The following is a description of a gene set: studied in species Mus musculus Mouse Gene Set: GOBP_CELLULAR_RESPONSE_TO_ALCOHOL Any process that results in a change in state or activity of a cell (in terms of movement, secretion, enzyme production, gene expression, etc.) as a result of an alcohol stimulus., and this is the list of marker genes: Jup, Drd2, Mir10b, Tnfsf4, Gpld1, Btg2, Akr1c18, Npas4, Foxo3, Hnrnpk, Cftr, Ces1d, Golph3, Sod2, Inhbb, Mir30a, Mlc1, Mir362, Aifm1, Dynapl1, Mir200a, Ahr, Acaca, Creb1, Fbp1, Fancb, Fos, Map4k1, Mir30e, Ptger2, Adcy8, Gramd1b, Adcy3, Scnn1b, Ces1b, Sgk1, Blm (NCBI Gene Id 12144), Spidr, Gramd1a, Glra2, Mir9-3, Mir10a, Cyp7a1, Ces1f, Ctnna1, Mir154, Dnmt3a, Pten, Rplp0, Abca1, Prkaa2, Brca1 (breast cancer 1, early onset), Ces1h, Sfrp1, Ptger3, Efna5, Cdh1, Ptgfr, Hdac8, Lancl2, Slc5a5, Adcy7, Gnai1, Rps6, Ugt1a1, Akt1, Rad51, Gnas, Mir145a, Hnf1a, Klf4, Arpc2, Adam15, Gpr155, Osbpl7, Glra1, Fdx1, Cdk4, Klf2, Slc23a2, Trp53inp1, Akap8, Cyp1b1, Gramd1c, Nfe2l1, Mir9-1, Adcy5, Sphk2, Hoxa1, Nr3c2, P2ry4, Ctnnb1, Dag1, Scnn1g, Ccl7, Recql5 (NCBI Gene Id 170472), Lrp6, Kcnmb1, Ptgdr, P2ry6, Mir152, Dynap, Nanog, Epha5, Lrp8, Grip1 (glutamate receptor interacting protein 1), Klf9, Ireb2, Prkce, Tnc, Itpr2, Ces1a, Prkaa1, Adcy6, Mir9-2, Ncam1, Larp1, Mdm2, Adcy2, Rps6-ps4, Mir496a, Mir296, Smo, Scnn1a, Ptch1, Cybb, Ucp1, Ace, Mir29c, Glra3, Adcy1, Ces1c, Pck1, Ces1g, Ces1e, Mir339, Inhba, Pax6, Ptger4, Prkd1